The following is a description of a gene set: Human Gene Set: HP_SUBARACHNOID_HEMORRHAGE species: Homo sapiens Hemorrhage occurring between the arachnoid mater and the pia mater. Subarachnoid hemorrhage, and this is the list of marker genes: F10, MAT2A, TGFBR1, TGFBR2, SMAD3, GP1BB, LOX, ITGA2B, FBN1, THSD1, ENG, ITGB3, FOXE3, MYLK (myosin light chain kinase), ACTA2, PRKG1, RASA1, ANGPTL6, ELN, SMAD2, COL3A1 (collagen type III alpha 1 chain), ITGA2, MYH11, ACVRL1, APP, HEY2, GDF2 (NCBI Gene Id 51423), TGFB3, SMAD4 (NCBI Gene Id 4089), THSD4 (NCBI Gene Id 79875), ZFX, GAA, TGFBR3, DOCK8, STIM1, CD109, ADA2, TGFB2, GP1BA, MFAP5